Given this list of marker genes Fxn, Mecp2 (methyl CpG binding protein 2), Slurp1, Pou4f1, Gaa, Cln8, Adarb1, Gch1, Scn1a, Large1, Cntnap2, Tcf15, Pnkd, Gbx1 (NCBI Gene Id 231044), Hottip, Tmem150c, Hexa, Atp8a2 (NCBI Gene Id 50769), Glra1, Prrt2, Cntnap1, Rnf170, here is a description of the gene set: Any process in which an organism voluntarily modulates its posture, the alignment of its anatomical parts. Mouse Gene Set: GOBP_NEUROMUSCULAR_PROCESS_CONTROLLING_POSTURE studied in species Mus musculus